Given this list of marker genes Actb, Smarcd2, Smarcd3, Ss18l1, Bcl7c, Brd9 (bromodomain containing 9), Arid1a, Bcl11b (NCBI Gene Id 78682), Smarce1 (SWI/SNF related, matrix associated, actin dependent regulator of chromatin, subfamily e, member 1), Pbrm1, Brd7, Bicral, Bcl11a, Smarcd1, Dpf3, Smarcc2, Ss18, Bcl7b, Bcl7a, Bicra, Smarcb1, Actl6a, Smarca4, Smarcc1, here is a description of the gene set: studied in species Mus musculus ATP-dependent chromatin remodelers Mouse Gene Set: REACTOME_ATP_DEPENDENT_CHROMATIN_REMODELERS